The following is a description of a gene set: Reactome Pathway: Zymostenol biosynthesis via lathosterol (Kandutsch-Russell pathway) studied in species Mus musculus electronically inferred by orthology from the curated human pathway This event has been computationally inferred from an event that has been demonstrated in another species.<p>The inference is based on the homology mapping from PANTHER. Briefly, reactions for which all involved PhysicalEntities (in input, output and catalyst) have a mapped orthologue/paralogue (for complexes at least 75% of components must have a mapping) are inferred to the other species. part of: Cholesterol biosynthesis, and this is the list of marker genes: Tm7sf2, Nsdhl, Dhcr24, Srebf2